The following is a description of a gene set: part of: Extracellular matrix organization studied in species Mus musculus electronically inferred by orthology from the curated human pathway This event has been computationally inferred from an event that has been demonstrated in another species.<p>The inference is based on the homology mapping from PANTHER. Briefly, reactions for which all involved PhysicalEntities (in input, output and catalyst) have a mapped orthologue/paralogue (for complexes at least 75% of components must have a mapping) are inferred to the other species. Reactome Pathway: Integrin cell surface interactions, and this is the list of marker genes: Itga2, Col2a1, Itga4, Itgb7, Itgb8, Itga3, Lum, Col6a6 (NCBI Gene Id 245026), Col4a5, Col5a3, Itga2b, Col9a1, Col13a1, Bsg, Col4a2, Col7a1, Col6a5, Spp1, Col8a2, Tnc, Ibsp, Icam4, Itga5, Col8a1, Vtn, Itgb5 (integrin beta 5), Icam2, Fgg, Itgb2, Cdh1, Icam5, Itgax, Comp, Itgal, Col4a6 (collagen, type IV, alpha 6), Col6a1, Col18a1